The following is a description of a gene set: species: Homo sapiens Tethering of late endosomes and lysosomes. Pathway ID: N01300. Pathway type: Reference. Pathway class: nt06125 Membrane trafficking (bacteria). Pathway Definition from KEGG: ARL8B == PLEKHM1 == RAB7 == HOPS Human Gene Set: KEGG_MEDICUS_REFERENCE_TETHERING_OF_LATE_ENDOSOMES_AND_LYSOSOMES, and this is the list of marker genes: VPS11, ARL8B, RAB7A, VPS18, VPS41, VPS33A, VPS16, PLEKHM1 (NCBI Gene Id 9842), RAB7B, VPS39 (VPS39 subunit of HOPS complex)